Given this list of marker genes SPIB, CCDC93, AKAP1, LCK, MTERF3, ABLIM1, PDE12, GSPT1, KANSL2, MARCHF5, URI1, RRAS2, MARK3, ETS2, IARS1, JADE1, TRIB2 (NCBI Gene Id 28951), TIMM9, HOOK2, DZIP1, CD3D, EDNRA, SCEL, AXL, DEGS1, QNG1, SIMC1, RCOR1, NCKAP1, PLD3, TSHZ2, TIMM23, PLD4, ID2, SFXN2, NSG2, CYB5A, LCLAT1, ITGAE, PDPK1, SIT1, SATB1, DHX57, EPB41L4A, RGS10, TPP2, SPRY1, GCOM1, H19, NEFH, CD28, SNAI3, SLAMF6, C16orf87, EIF4ENIF1, BRDT, CCPG1, CHCHD3, PLXDC1, IFTAP, SPATS2, UTP25, SH2D1A (SH2 domain containing 1A), TRIP12, ACTN1, RGS14, SENP2, DARS1, DGKA, FAM91A1, REV1, P2RX1, CBL, RAD17, SLC35D1, PHLDA1, EIF4G3, UCHL3, CTSB, WDR26, MPZL2, AKAP9, TMEM50B, SERAC1, NRDC, C19orf48P, NRP1, USP9X, YTHDC1, ICE1, EGR1, PDCD10, IL34, MORC1, CPEB4, KLHL42, POGLUT2, LGALSL, STT3B, PURA, ITPR2, HUWE1, NDUFS4, NAF1, SH3KBP1, MBP, EDEM1, UVRAG, CCNH, CAMKK1, ZNF14, CSNK2A1 (casein kinase 2 alpha 1), POPDC3, ANKS3, SLC29A3, PPARGC1B, CNTNAP2, TMEM126A, TPST1, NUP88, GZMA (NCBI Gene Id 3001), CAMKV, CREBZF, CS, EIF2AK3, ARHGEF10L, LYST, NOL7, ZFP36L1, ID3, MGA, DNAJC5, RAG1, ABCE1, MTHFD1, TGFBR1, PPP2R5A, CLK2, KRT81, NRIP1, DTX1, PNO1, ZNF426, PTCRA, ZMAT3, FBLN2 (NCBI Gene Id 2199), LY6D, HERC1, NKTR, CTPS1, MIX23, LEF1, MPC1, EIF2S1, IFT25, EPCAM, BCAT1, HIBADH, CCR9, UPB1, GID4, BNIP3L, PTPRF, SLAIN1, ARPP21, MED10, SLC12A7, NDEL1, BMAL1 (basic helix-loop-helix ARNT like 1), RPF2, HERPUD2 (HERPUD family member 2), BID, CFHR2, CARD10, ZNF451, KDM3A, NAB2, RPL22L1 (ribosomal protein L22 like 1), RSL1D1, NR3C1, SURF2, DESI1, GFRA1 (NCBI Gene Id 2674), SNRK, NDUFAF4, PKD1, ZMPSTE24, PRKCB, PFN2, RYR1, DICER1, SKP1, RAPGEF6, N4BP2L1, TMEM131, U2SURP, GPHN, SLC5A9, TASOR2 (transcription activation suppressor family member 2), here is a description of the gene set: from publication Belyaev NN, Biró J, Athanasakis D, Fernandez-Reyes D, Potocnik AJ (PMID 22581009) Genes down-regulated in adult DN2 thymocytes versus adult DN3 thymocytes. Development of T-cells provides a unique opportunity to study cell-fate determination due to the accessability and the well defined stages of developmental stages. In order to understand the genetic programs underlying fetal and adult T‑cell fate specification we subjected highly purified fetal and adult T-cell progenitor populations to a genome‑wide transcriptional analysis. The aim was to identify molecular elements that govern T-cell fate specification as a whole but ultimately to isolate elements that were specific for a given population in a specific developmental window. Human Gene Set: GSE24142_DN2_VS_DN3_THYMOCYTE_ADULT_DN studied in species Homo sapiens